The following is a description of a gene set: The network of interconnected tubular and cisternal structures located at the convex side of the Golgi apparatus, which abuts the endoplasmic reticulum. Human Gene Set: GOCC_CIS_GOLGI_NETWORK studied in species Homo sapiens, and this is the list of marker genes: TRAPPC6A, COPZ2, SLC35C2, GOLGA6L7, GOLGA5, MAP6D1, MAN2A1, AKAP9, TRIP11, RAB3GAP1, GOLGA6B, B3GAT3, GOLGA8H, GOLGA8G, BOK, GOLGA6A, GORASP1, HOOK3, LIMK2, BET1, RAB29, GOSR1, GOLGA8T, GOLGB1, RAB18, TRAPPC6B, RNF183, GOLGA8DP, GOLGA8IP, GOLGA8F, GOLGA6C, FKTN, GOLGA8M, LRPAP1, GBF1, TMED10, BLZF1, UBXN2A, TRAPPC3L, GOLGA8O, GOLGA8N, KDELR1, BCL9, KDELR2, TMED5 (transmembrane p24 trafficking protein 5), HLA-G, GOLGA8R, PMEL, ANGEL1, VPS13B, GOLGA8A, TRAPPC3, GORASP2, SCYL1, ATP2C1, PIK3R1, GOLGA8B, IFT20, KDELR3, GOLGA8CP, RETREG1, GOLGA8S, MAP6, TMEM165, GOLGA8Q, GOLIM4, GOLGA2, COG3, GOLGA6D (NCBI Gene Id 653643), RAB30, GOLGA8K, GOLGA8J, YIPF6, AZIN2, SCFD1, YIPF7, GPR108